Given this list of marker genes CD36, LGALS9, IL23R, IDO1, HLA-G, MAPK11, IL16, IL23A, TLR9, IL17A, IRF5, TNFSF4, CCL19, IFNG, SYK, IRF8, TLR2, CCR7, TLR3, MDK, MAPK14, LTB, TIRAP, HSPD1 (NCBI Gene Id 56733), TRAF6, RELA, LAPTM5, AGER, HMGB1, SCIMP, PLCB1, RIPK2, CD40LG, DEFB124, CLEC7A, IL12B, PLCG2, UNC93B1, ISL1, CD40, TLR4, IRF1, LEP, here is a description of the gene set: Human Gene Set: GOBP_POSITIVE_REGULATION_OF_INTERLEUKIN_12_PRODUCTION Any process that activates or increases the frequency, rate, or extent of interleukin-12 production. species: Homo sapiens